Given this list of marker genes PLK3, CLCF1, ANXA1, RBKS, MGST2, TGFBR2, PDPN (podoplanin), GNA15, CD2AP, LHFPL2, TRADD, ARSJ, PROCR, SEC24D (SEC24 homolog D, COPII coat complex component), SLC16A3, RUNX2, DRAM1, CPQ, SHC1, TES, COL1A2, RAB11FIP1, CNN2, S100A4, ACSL1, LAMB1, PLAUR, IGFBP6, FHL2, SRPX2, MS4A4A (NCBI Gene Id 95933), LRRFIP1, PLA2G15, LGALS3, SAT1, AMPD3 (NCBI Gene Id 272), P4HA2, ANXA2, LILRB3, YAP1, RABGAP1L, SQOR, LTBP2, TEC, ASL, CCR5, PTPRC, TRPM2, NRP1, LCP1, HK3, ALOX5, CSTA, TIMP1, PTGER4, BDKRB2, WIPF1, PLS3, CLEC2B, RELB, THBS1, CTSC, TYMP, MYH9 (NCBI Gene Id 65212), DOK3, TMBIM1, WWTR1, UCP2, SERPINA1, COL8A2, CTSZ, MAFB (NCBI Gene Id 9935), MSR1, TNFRSF11A, POLD4, DSC2, FPR3, TNFRSF1B, MFSD1, RHOG, BATF, ARPC1B, ITGA4, ALDH3B1, C5AR1, HEXB, SIGLEC9, COLGALT1, DSE, THEMIS2, MCUB, MAPK13, FCGR2A, COL5A1, PTPN6, MGAT1, S100A11, RRAS, ICAM3, FURIN, FES, CD14, CDCP1, COL1A1, ITGA5, LAIR1, TCIRG1, RBM47, ITGB2, ARHGAP29, TGFBI, STXBP2, CYTIP, EHD2 (EH domain containing 2), LILRB2, ADAM12, SLC10A3, COPZ2, MVP, KYNU, BNC2, NPC2 (NCBI Gene Id 10577), CEBPB, GCNT1, C1orf54, CASP4, MAN1A1, CYBRD1, NOD2, PLAU, CTSB, MAN2A1, FCGR2B, SLC11A1, SWAP70, RBMS1, BLVRB, SCPEP1, SLAMF8, EMP3, PLBD1, LY75, ANXA4 (NCBI Gene Id 307), MYOF, PIGP, CASP8, CYTH4, SIGLEC7, FMNL1, IQGAP1, TNFRSF1A, PHF11, IL15RA, TLR4, LCP2, RAC2, LOX, ST14, PTPN22, VAMP5, SFT2D2, HEXA, TNFAIP8, IFI30, VDR, GRN, EFEMP2, THBD, LY96, MYO1F (NCBI Gene Id 4542), STAT6, ITGAM, SYPL1, CAVIN1, PYGL, CAST, TRIM38, CASP1, SYNGR2, TRIM22, LGALS1, NCF2, ENG, RAB32, FHOD1, CD4, IL4R, LTBP1, MRC2, IL1R1, LAPTM5, ACP3 (acid phosphatase 3), SERPINE1, RAB27A, FXYD5 (FXYD domain containing ion transport regulator 5), TLR2, MAN2B1, HFE, CLIC1, ELF4, FOLR2, CASP5, CHI3L1, SP100, SH2B3, FNDC3B, NCF4, TNFAIP3, TGOLN2, DAB2, CRYBG1, S100A13, UAP1, STAB1, ZNF217, DCBLD2, here is a description of the gene set: Genes correlated with mesenchymal type of glioblastoma multiforme tumors. studied in species Homo sapiens Human Gene Set: VERHAAK_GLIOBLASTOMA_MESENCHYMAL The Cancer Genome Atlas Network recently cataloged recurrent genomic abnormalities in glioblastoma multiforme (GBM). We describe a robust gene expression-based molecular classification of GBM into Proneural, Neural, Classical, and Mesenchymal subtypes and integrate multidimensional genomic data to establish patterns of somatic mutations and DNA copy number. Aberrations and gene expression of EGFR, NF1, and PDGFRA/IDH1 each define the Classical, Mesenchymal, and Proneural subtypes, respectively. Gene signatures of normal brain cell types show a strong relationship between subtypes and different neural lineages. Additionally, response to aggressive therapy differs by subtype, with the greatest benefit in the Classical subtype and no benefit in the Proneural subtype. We provide a framework that unifies transcriptomic and genomic dimensions for GBM molecular stratification with important implications for future studies. from publication Verhaak RG, Hoadley KA, Purdom E, Wang V, Qi Y, Wilkerson MD, Miller CR, Ding L, Golub T, Mesirov JP, Alexe G, Lawrence M, O'Kelly M, Tamayo P, Weir BA, Gabriel S, Winckler W, Gupta S, Jakkula L, Feiler HS, Hodgson JG, James CD, Sarkaria JN, Brennan C, Kahn A, Spellman PT, Wilson RK, Speed TP, Gray JW, Meyerson M, Getz G, Perou CM, Hayes DN, Cancer Genome Atlas Research Network (PMID 20129251)